The following is a description of a gene set: species: Homo sapiens The chemical reactions and pathways resulting in the breakdown of purine nucleoside, one of a family of organic molecules consisting of a purine base covalently bonded to a sugar ribose (a ribonucleoside) or deoxyribose (a deoxyribonucleoside). Human Gene Set: GOBP_PURINE_NUCLEOSIDE_CATABOLIC_PROCESS, and this is the list of marker genes: PNP, GDA, XDH, MAPDA, NUDT1, ADA2, ENPP4, ADA